Given this list of marker genes PALM2AKAP2, SPRTN, SLC17A5 (solute carrier family 17 member 5), PRND, SPSB4, JRK, LRRC41, C1orf210, KDM2B, APPBP2, IFT122, YTHDF1, SEC63, TCF12, ARNT2, FOXP4, NDOR1, RBMS2, NUDT19, GAB2, SSH2, AQP2, CALCRL (calcitonin receptor like receptor), FMO5, HOXA13, ANGPT4, SLC25A12, TRPC1, ADARB2, RNF24, NUFIP2, PTEN, SC5D, FBXL20, PPP3CB, TRMT13, TYW3, CCP110, CEACAM7, GPR62, PLEKHM1, GDNF, HIVEP3, PODNL1, LARP1, RMI1, CCNT1, GIPC3, CXXC4, SIDT1, SMPD1, PPP2R2B, TMEM127, NBPF4, ZNF322 (zinc finger protein 322), WWC2, CLSPN, CACNA1I, AP4S1, ORAI2, BRPF3, GABRA1, ARRDC3, RPL28, GUCD1, LRRTM3, CREB5, YEATS2, CMKLR1 (NCBI Gene Id 1240), SMAD6, PADI3, PSD3, JADE1, EGR3 (early growth response 3), RC3H1, CHL1, CKAP4, AKAP13 (A-kinase anchoring protein 13), EEF2K, TFAP2A, HOOK3, CCL28, ZNHIT6, SRR, CAV1, CMTR2, MARCKSL1, PRR14L, SIKE1, AK3, DDX11, FGF14, IFI35, BTRC, NECTIN1, NFAM1, NPLOC4, ZNF609, NXF1, PLOD1, RYBP, NLRP14, ZNF483, ARMC5, SAR1A, SUDS3, SLC6A4 (solute carrier family 6 member 4), FMOD, FAM120C, RD3, ABCB8, FOXP1, KCNK2, APBB2, GRK6, TPI1, KPNA6, RORC, COL4A5, DCTN5, FAM124A, TANGO2, TFB1M, TCAP, SYNGR1, ARF6, HAPSTR1, FBXO33, ATP8A1, NF2, TMEM41B, CRTC1, SEC14L1, PTGES3L, NOS1 (NCBI Gene Id 4842), LRRC31, AHI1, NRP1, SRFBP1, PHF21A (PHD finger protein 21A), TTC22, SLC22A14, TCTN3, DAB2IP, GPI, RAB11FIP3, TRABD2B, RARB, ACP6, NAT8L (N-acetyltransferase 8 like), RIMS4, TUB, ZBTB8B, IPO9, MIER3, PGAP2, YAP1 (NCBI Gene Id 10413), KCNB1, here is a description of the gene set: Human Gene Set: MIR1285_3P from publication Chen Y, Wang X (PMID 31504780) Genes predicted to be targets of miRBase v22 microRNA hsa-miR-1285-3p in miRDB v6.0 with MirTarget v4 prediction scores > 80 (high confidence targets). studied in species Homo sapiens